Given this list of marker genes Ikbkb, Nfkb1, Traf6, Ngf, Ubc, Irak1, Rela, Uba52rt, Uba52, Rps27a, Ubb, Ngfr (NCBI Gene Id 18053), Sqstm1, Nfkbia, here is a description of the gene set: studied in species Mus musculus Mouse Gene Set: REACTOME_NF_KB_IS_ACTIVATED_AND_SIGNALS_SURVIVAL NF-kB is activated and signals survival